Given this list of marker genes Klf2, Jun, Junb, Hspa1a, Tsc22d3, Fos, here is a description of the gene set: Cytokines mediate cell-cell communication in the immune system and represent important therapeutic targets. A myriad of studies have highlighted their central role in immune function, yet we lack a global view of the cellular responses of each immune cell type to each cytokine. To address this gap, the authors created the Immune Dictionary, a compendium of single-cell transcriptomic profiles of more than 17 immune cell types in response to each of 86 cytokines (>1,400 cytokine-cell type combinations) in mouse lymph nodes in vivo. A cytokine-centric view of the dictionary revealed that most cytokines induce highly cell-type-specific responses. For example, the inflammatory cytokine interleukin-1β induces distinct gene programmes in almost every cell type. A cell-type-centric view of the dictionary identified more than 66 cytokine-driven cellular polarization states across immune cell types, including previously uncharacterized states such as an interleukin-18-induced polyfunctional natural killer cell state. species: Mus musculus Genes negatively differentially expressed in cell type: CD4+ T cell upon treatment with cytokine: SCF in mouse lymph nodes in vivo. from publication Cui A, Huang T, Li S, Ma A, Pérez JL, Sander C, Keskin DB, Wu CJ, Fraenkel E, Hacohen N (PMID 38057668) Mouse Gene Set: CUI_T_CELL_CD4_SCF_RESPONSE_DN